Given this list of marker genes H2ac18, Abl1, Tbl1xr1, Tbl1x (NCBI Gene Id 21372), H2ac4, H3c7, H4c12, H4c4, H2ac8, H2ac15, H2bc26, H3c11, H2bc14, Paxip1, H2ac6, H2ab2, H3c1, H4c9, H2bc4, H2ac24, Pagr1a, H3f3a, Rxra, Hdac3, H3c13, H2ac10, H2bc9 (NCBI Gene Id 319182), H3c4, H4c11, H2bc8, H2ax (NCBI Gene Id 15270), H2bc12, H2bc15 (H2B clustered histone 15), H3c8, H2bc6, H2aj, H2bc11 (NCBI Gene Id 319183), H2ac12, H2bc13, H2bc23, Rbbp5, Kmt2d, H4c17 (H4 clustered histone 17), H3c6, H3f3b, H4c16, H4c14, H2ac19, H3c15, H3c10, Kdm6a, H3c2, H2bc7, H2bc21, H2bc1, H2ac22, H4c2, Ash2l, H2bc24, Wdr5, H4c6, H2az2, H4c1, Gps2, H2ac11, H3c3, H4c3, Ncor2, H4c8, H4c18, H3c14, H2bc3, H2bc22, H2ac20, H2ac7, H2ab1, H2ab3, H2ac13, H2ac23, here is a description of the gene set: Mouse Gene Set: REACTOME_EPIGENETIC_REGULATION_OF_GENE_EXPRESSION_BY_MLL3_AND_MLL4_COMPLEXES Epigenetic regulation of gene expression by MLL3 and MLL4 complexes studied in species Mus musculus